The following is a description of a gene set: from publication Sanda C, Weitzel P, Tsukahara T, Schaley J, Edenberg HJ, Stephens MA, McClintick JN, Blatt LM, Li L, Brodsky L, Taylor MW (PMID 16800785) Genes down-regulated in epithelial cells (6h): IFNG versus IFNG and interferon alpha. Human Gene Set: GSE5542_IFNG_VS_IFNA_AND_IFNG_TREATED_EPITHELIAL_CELLS_6H_DN Type I and type II interferons (IFNs) bind to different cell surface receptors but activate overlapping signal transduction pathways. We examined the effects of a type I IFN (IFN-acon1) and a type II iFN (IFN-g1b) on gene experession in A549 cells and demonstrate that there is a common set of genes modulated by both IFNs as well as a set of gene specifically regulated by each, reflecting the activation of different signaling pathways. In particualr, IFN-g induced many more genes of the signaling pathways, apoptosis, and cytokine interactions than did IFN-a. Even with genes induced by both IFNs there were distinctive quantitativive differences in expression. IFN-g1b plays a major role in the induction and regulation of the complement pathway. Previous work has shown a synergistic antivral and antiproliferative effect of type I and type II IFNs in cell culture and in the treament of tumors in mice. We demonstrate that a majority of genes showed and additive effect of IFN-acon1 and IFN-g1b, but a subset of gene is synergistically induced; these incluce ISG10, MX2, OAS2, and other genes known to be involved in the antiviral response, TRAIL (TNFSF10) and caspases involved in apoptosis and chemokine genes RANTES, CXCL10, and CXCL11. Greater than additive transcription of some of these genes in the presence of both IFNs was confirmed by real-time kinetic RT-PCR. Elevated induction of many of these genes may be sufficient to explain the synergistic antiviral and antitumor effects of this combination of IFNS in vivo. species: Homo sapiens, and this is the list of marker genes: NECAP1, SLC7A8, BID, IDH3A, SDHC, FOXD2, MRPS10, COQ6, SLC1A5, PITPNM1, SRFBP1, AZI2, STAT4, ABHD11, FBXO31, AGO1 (argonaute RISC component 1), UGT2B17, FBXO25, CCDC115, SS18L1, DHX33, CXCL13, EIF2B1, SSPN, ETNK1, DAAM1, MIF, DNAJB4, EXOSC5, EHD3, PITHD1, SLC25A28, SLC35G1 (NCBI Gene Id 159371), FAM110C, SMG1, BSCL2, FCF1 (NCBI Gene Id 51077), OSBPL3, RPS27, CYP51A1, SAR1A, PIM1 (Pim-1 proto-oncogene, serine/threonine kinase), STAT1, PAK4, AFG1L, EIF2B5, ERLIN2, JAGN1, RAD1, CFAP418, MTRES1, ATP5F1D, MSR1, ACVR1B, OSGEP, RPS3, ING3, ADAMTS7, PDE4B, TMEM64, PRPF39, PIK3R3, TAF4B, DHX58, B3GLCT, MAP3K1, HEPH, EXOC3L4, MAP7D1, SLC30A1, ABHD12, RPL38, SAG, TYROBP, CA9, FIBP, MICU3, PNPLA2, ADAR, ARHGAP21, MYCBP2, HADHB, TRAPPC6A, SLC48A1, HTRA2, ECI1, PDGFA, NOXO1, LAPTM5, PIGF, ARGLU1, MFHAS1, NRIP1, DNAJC10, RPS9 (NCBI Gene Id 6203), PSMA4, RTCA, NLRP6, RENBP, ANKRD52, EIF5A2, TFAM, AFG3L2, ORMDL2, DESI2, ERAP1, POMGNT1, DDX6, ZNF385A, TLCD3B, RPL24, SLC28A2, EPHA4, KIF1C, F8A1, ABI2, AGA, BCOR, TRMT11, MMUT, PEX11A, NCOA1, PIK3R1, FOXO3, MAGED1, DMAC2, ECI2, UTP20, DYNLT2B, QRICH1, TNK1, PTMS, CFAP141, P2RX4, IL15, TBC1D9, KIAA1217 (KIAA1217), CAMSAP2, F9, METAP1D, CSAD, IDH2, NDUFC2, RFTN1, TOR1AIP2, EIF3K, CLYBL, CELF4, ICAM2, SEPTIN8, STARD10, NIPA1, SMPD2, RBIS, PRKAR1B, SERPINB7, LGALS1, KBTBD8, COX10, PLCG1, RMND1, BOLA2, FUT11, CLCN7, LAMC2, ACAT1, KCNK5, MECR, PPIP5K1, MTR, TUBB6, MFSD3, SUSD6, FAM114A1, NUDT12, KEAP1, RPL41, RIC8A, IPO11, MEF2D, SOCS7, CLDN8, EIF4A1, WHAMM, SENP5, LMNA, CORO1C (NCBI Gene Id 23603), KANK3, MYO7A (myosin VIIA), SH2D1A, CCN3, HUWE1, CAPN2 (NCBI Gene Id 824), CERS6, SNX21, NR2C2AP, DPM2 (dolichyl-phosphate mannosyltransferase subunit 2, regulatory), LRRC66, AHDC1, OST4